The following is a description of a gene set: Genes in the cancer module 181. species: Homo sapiens Human Gene Set: MODULE_181, and this is the list of marker genes: FAM13A, REG1B, ATOSB, COL10A1, ALDOB, ASIC3, GRK3, S100A4, ZP2, MAPK13, HMHB1, MET, EXOSC2, PNOC, ADRA1D (NCBI Gene Id 149), TNFRSF21, UCN, KIAA0586, GAGE12G (NCBI Gene Id 645073), L1CAM, LRCH4 (NCBI Gene Id 4034), POM121L9P, VAMP1, HOXD10, CD86, RIMS2, CLDN5, FCN2, ECE2, TNFRSF13B, RIBC2, CYP2E1, ACSL6, LY6G6C, AANAT, GIP, RAD51D, AQP8, CDH1, SHBG, SLC17A3, MPZ, TRIM10, SLC29A2, MSI1, PGC, HAP1, AOC1, GRK1, TAOK2, EXD2, RCVRN, DHRS2, ZBTB24, H6PD, TAGLN3, CYP2F1, GRM2, RHBDL1, GALNS, MAGEA9, RGS9, LILRA4, GLE1 (GLE1 RNA export mediator), SIX6, SLC22A6, KCND3, TNFRSF6B, GRIK5, PI3, PZP, MLC1, CDH16, CELA2B, LORICRIN, ARFGAP3, MPZL2, PGAM2, ATP6V1G2, TACC2, SIX3, CDK5R2, AMMECR1, EMID1, NAT8, S1PR4, SLC18A1, CCL7, REPS2, SFTPC, SERPINA4, ALOX15, CCL16, MYH2, HTR4, ATP4A, TBXT, TYR, EPM2A, AKAP3, CCDC9, SPC25, SPART, ADA, WASF2, SCGN, GALR3, JAKMIP1, TEX28 (NCBI Gene Id 1527), SMAGP, NTNG1, AKAP7, BRMS1, GFPT2, RPH3A, PRF1, AMELX, ABCB9, PTH2R, PPP6R2, PKP3, DNASE1, H3C6, SPINK2, CXCL5, CSTF2, HBB, WNT10B, DKK4, ODF1, NDRG2, PPT2, SLIT3, RAC3, KRT2, SCAMP5 (secretory carrier membrane protein 5), PIGO, GTSE1, IKBKG, REG1A, PIK3IP1, DEFA1, MTA2, SLC7A4, B3GNT3, SLC6A2, CEACAM3, CLDN9 (claudin 9), MYCL, CEACAM4, PLIN1, TBX19, SOX10, PDE4A, SEMA7A, ZNF157, THRA, TNFRSF10D, ZC3H14, HOXB1 (NCBI Gene Id 3211), MAGEA4, MTHFR, BMP10, NRXN1, GNG7, CRCP, GNG4, SEZ6L (seizure related 6 homolog like), CSH2, HRK, PAX7, HSD17B1, CHRNB4, NTRK1, MLLT1, NR2E3, GPR3, FAM131B, RBMXL2, MPO, NSG1, ADRA2C, KRT32, RASL10A, QPCT, ABCA1, PPP4R2, CD82, NCALD, TFAP2B (NCBI Gene Id 7021), BARX2, CALB2, PTP4A3 (NCBI Gene Id 11156), EIF4EBP1, SLC17A7, NRG2, CCNF, IVL, ADAM20, HCRT, CD3E, ABCC8, PSD, MLANA, MAGEC1, LCE2B, MAGI1, KIF21B, TBR1, LYPD3 (LY6/PLAUR domain containing 3), RRH, ZNF143, FUT3, KCTD17, GNMT, MYEF2, NELFA, SSX4, FKBP6, FAT2, LEFTY1, TRIM15, SYT5, CHST3, TNFRSF10C, CTSG, RAP2C, FANCL, PTPRN, STATH, GREM1, DNAJB12, CEP135, APC2, CLDN14, CCKAR, HOXD13, TRPM2, S1PR2, CTAG1B, MACIR, CD33, HOXC11, KCNQ3, CHP2, SLC7A11, SNAP25, KCNN1, PIGL, HAAO, CYP2C19, ACTL6B, COL2A1, NEMF, ADGRL3, REN, PPP3CA, NECTIN1 (NCBI Gene Id 84853), DMBT1, EIF1AY, SLC22A18AS, SCN2B, PRELID3A, PROC, RECQL5, ENTPD2, FZR1, NR0B2, MAT1A, CNTN6, KIF1C, BRD4, CCK, KRT33B, EDA, TRIB1, PRB4, CHRNB1, CD4, CASP2, INHBC, SSTR2 (somatostatin receptor 2), TP63, UNC119B, LRIT1, RCE1, PSCA, ELAVL2, KRT13, CYP27B1, RUNDC3A, CHST1, TBX1, MYOZ3, SIT1 (signaling threshold regulating transmembrane adaptor 1), CBLN1, SRPK3, EPOR, ASIP (NCBI Gene Id 434), ING1, NNAT, CFAP410, ISG20L2, GAS8, FLT1, HPR